Given this list of marker genes Gjd4, Capn3, Sox15, Xirp1, Snhg15, Klf5, Kpna1, here is a description of the gene set: Mouse Gene Set: GOBP_SATELLITE_CELL_ACTIVATION_INVOLVED_IN_SKELETAL_MUSCLE_REGENERATION species: Mus musculus The process that initiates skeletal muscle satellite cell division by causing it to move from quiescence to the G1 stage of the cell cycle. The cell swells and there are a number of other small changes. The cells then start to divide. Following cell division the cells will differentiate. In adult muscle, satellite cells become activated to divide and differentiate in response to muscle damage.